The following is a description of a gene set: species: Homo sapiens Human Gene Set: GOMF_OXYGEN_BINDING Binding to oxygen (O2)., and this is the list of marker genes: CYP3A5, CBS, ADGB, CYP1A1, CYP2E1, CYGB, SOD2, CYP19A1, HBA2, CYP3A7, ALB, HBB, CYP2F1 (NCBI Gene Id 1572), ENSG00000274276, HBA1, HBG1, MB, HBD, CYP3A4, HBM, HBG2, HBE1, CYP4B1, CYP2A7, NGB, CYP2C19, HBZ, CYP2C18, HBQ1, CYP26A1, TDO2, CYP8B1 (cytochrome P450 family 8 subfamily B member 1), CYP17A1